Given this list of marker genes CDC25C, PDIK1L, PKMYT1, USP17L2 (ubiquitin specific peptidase 17 like family member 2), STK35, CDC25B, NDC80, CCNB2, CDC25A, here is a description of the gene set: Human Gene Set: GOBP_G2_MI_TRANSITION_OF_MEIOTIC_CELL_CYCLE The cell cycle process in which a cell progresses from meiotic G2 phase to M phase of meiosis I. studied in species Homo sapiens